The following is a description of a gene set: Mouse Gene Set: TABULA_MURIS_SENIS_SPLEEN_PLASMA_CELL_AGEING studied in species Mus musculus from publication Tabula Muris Consortium (PMID 32669714), and this is the list of marker genes: S100a8 (NCBI Gene Id 99591), Sp140l2, Rgs10, Slpi, S100a9, Camp